The following is a description of a gene set: studied in species Homo sapiens from publication Chen Y, Wang X (PMID 31504780) Human Gene Set: MIR24_3P Genes predicted to be targets of miRBase v22 microRNA hsa-miR-24-3p in miRDB v6.0 with MirTarget v4 prediction scores > 80 (high confidence targets)., and this is the list of marker genes: MAGI1, CDK16, STX5, CALCR, TMEM178B, AVL9 (AVL9 cell migration associated), ATRX, LIMD2, BCL7A, BNIP3L, IFFO2, ATAD2B, MTHFR, PTPRF, FAS, SNN, HNF1B, CD28, VCPIP1, FADS6, NAIF1, NRP2, GBA2, MBD6, C17orf49, MLEC, TRPC4AP, ERC2, SCML2, FASLG, USP54, NEMP2, ST3GAL1, ZCCHC14, TBC1D22B, TNS1, FAM168B, MRPL4, PLCH1, NAV2, ICA1L, PPP1R16B, DNAJB12, GNE, GRIA3, UGT2B10, CITED4, CDKN1B, ATP13A2, CCDC157, KCNJ2, LSM4, MTMR14, ABHD2, MTUS2, BCL2L11, MICAL2, ATP5MJ, PITPNC1, MVB12B, STX6, CHD5, CHST4, ELL, KPNA4, UCK1, PTGER4, COP1, CIDEA, TEX48, ZFR2, NFAT5, ZNF217, FRMD7, B3GALT5 (beta-1,3-galactosyltransferase 5), SESN1, LAMC1, RAP1A, TMEM50B, FURIN, AGPAT1, ZNF697, HEG1, SLC6A6, TNFRSF19, PURA, USP20, PER1, ZXDC, C8orf58, LRPAP1, PPIL6, RANBP10, SLC12A6, APBB2 (amyloid beta precursor protein binding family B member 2), GALNT15, KIF3C, CACHD1, CRAT, CDX2, ZMYM3, RAP2C, GAD1, TMEM121B, SLC1A7, PRKCH, SH2B3, SSTR1, ARK2C (arkadia (RNF111) C-terminal like ring finger ubiquitin ligase 2C), LMBR1L, RPS6KB1, PRELID1, VXN, FGF11 (fibroblast growth factor 11), ZBTB44, APPL2, TSPAN14, SCML1, CDK17, GRIP1, KCTD21, RALA, PAK4 (p21 (RAC1) activated kinase 4), KCNB1, NIPSNAP1, SLC39A3 (NCBI Gene Id 92729), MAPKAPK2, CMTM4, TRPM6, POLR3D, CNOT6, TAOK1, SLC16A2, CTNS (NCBI Gene Id 1497), LPAR6, TOR2A, MATR3, GSK3B, NTSR1, PLOD2, RNF2, SPAG9, SRL, STRADB, CDV3, XIAP, TMEM209, ZXDA, TTC17, DLL1, NSD2, PLPPR4, ACVR1B, ADPGK, STC2, NFXL1, NDRG4, PLCL2, CDH7, ABCB9, DLGAP4, SNCAIP, AMOTL2 (NCBI Gene Id 51421), STAT2, CAMK2B, VGLL3, RSBN1L (NCBI Gene Id 222194), EXOG, PAQR3, MBOAT7, PDGFRB, ZXDB, DVL3, SPATS2L, PIM1, ZCRB1, NUP210, TRIM55, ADSS1, NDUFAF4, GCNA, DENND10, ORAI2, DCAF11, PRDM1, VANGL2, C17orf78, ANKRD44, MIX23, NCOA5, DUSP16, MNT, VPS53, DLC1, MOB3C, SSR1, RER1, TBC1D24, TRAF7, NDST1, PDP2, BVES, MATN3, FAM78B, SEMA4A, KLHL1, IFNG, TLN2, NRP1, NLK (nemo like kinase), MTCL2, CRIPT, FBLIM1, TSC22D2, MED8, CLCN3, RASA1, VSTM4 (NCBI Gene Id 196740), SEMA4B, SFXN5, SEC14L5, MGAT4A, MT1M, DYRK2, DGKK, INSIG1, TMEM161B, NDST3, AGPS, MPDU1, MARCKSL1, C2orf72, ZNF395, CASTOR2, NEFM, BTAF1, PER2, NOS1, DUSP8, SCARB1, MAPK7, PTPRD, YOD1, PIM2, MIDN, SMAGP, SNTB1, SKIDA1, SLC30A2, SETD9, GBX2, EDA2R, KLHL3, TAF7L, RNF138, TOP1, FST, GAL3ST3, RAP1B (NCBI Gene Id 5908), JADE2, BOK, PLEKHH2, PPM1K, APBA1, B4GAT1, LOX, MIA3, RUBCN, KDM5A, JRK, KCNK2, LIMD1, ZNF572 (zinc finger protein 572), RBBP4, EBF2, USF3, AAK1, ADD2, NEMP1, BTN2A2, TMTC1, UGCG